The following is a description of a gene set: Mouse Gene Set: GOBP_NEGATIVE_REGULATION_OF_RESPONSE_TO_TYPE_II_INTERFERON Any process that decreases the rate, frequency or extent of a response to type II interferon (interferon-gamma). Response to interferon gamma is a change in state or activity of a cell or an organism (in terms of movement, secretion, enzyme production, gene expression, etc.) as a result of an interferon-gamma stimulus. species: Mus musculus, and this is the list of marker genes: Ptpn2 (protein tyrosine phosphatase, non-receptor type 2), Parp14, Arg1, Otop1, Pparg, Dnaja3